Given this list of marker genes Tnik, Rapgef2, Espn, Nherf1, Hnf4a, Atp8b1, Ezr, Prl2c2, Stx2, Podxl, Fscn1, Pld1, Klf5, Rapgef6, Rap1gap, Vil1, Myo1a, Rdx, Stk26, Rap2a, Pls1, here is a description of the gene set: Formation of a microvillus, a thin cylindrical membrane-covered projection on the surface of a cell. Mouse Gene Set: GOBP_MICROVILLUS_ASSEMBLY studied in species Mus musculus